The following is a description of a gene set: Adrenoceptors Mouse Gene Set: REACTOME_ADRENOCEPTORS studied in species Mus musculus, and this is the list of marker genes: Adra2a, Adrb3, Adra2b, Adrb1, Adra1a, Adra1b, Adra1d, Adra2c, Adrb2